The following is a description of a gene set: part of: Diseases associated with the TLR signaling cascade Myeloid differentiation primary response (MyD88) is an adaptor protein that mediates intracellular signaling pathways evoked by all Toll-like receptors (TLRs) (except for TLR3) and several interleukin-1 receptors (IL-1Rs) (Medzhitov R et al. 1998). Upon ligand binding, TLRs hetero- or homodimerize and recruit MyD88 through their respective TIR domains. Then, MyD88 oligomerizes via its death domain (DD) and TIR domain and interacts with the interleukin-1 receptor-associated kinases (IRAKs) to form the Myddosome complex (MyD88:IRAK4:IRAK1/2) (Motshwene PG et al. 2009; Lin SC et al. 2010). The Myddosome complex transmits the signal leading to activation of transcription factors such as nuclear factor-kappaB (NFkB) and activator protein 1 (AP1).<p>Studies have identified patients with autosomal recessive (AR) form of MyD88 deficiency caused by homozygous or compound heterozygous mutations in MYD88 gene leading to abolished protein production (von Bernuth et al. 2008). AR MyD88 deficiency is a type of a primary immunodeficiency characterized by greater susceptibility to pyogenic bacteria such as invasive pneumococcal disease manifested in infancy and early childhood. Patients with MyD88-deficiency show delayed or weak signs of inflammatory responses (Picard C et al. 2010; Picard C et al. 2011).<p>Functional assessment of MyD88 deficiency revealed that cytokine responses were abolished in patient-derived blood cells upon stimulation with bacterial flagellin, which is recognized by TLR5 (von Bernuth et al. 2008). An NFkB luciferase reporter gene assay using human embryonic kidney 293 (HEK293T) cells showed that MyD88 variants, S34Y, E52del, E53X, L93P, R98C, and R196C, were compromised in the ability to enhance NFkB activation (Yamamoto T et al. 2014). The molecular basis for the observed functional effects (reported for selected mutations) probably faulty Myddosome formation due to impaired MyD88 oligomerization and/or interaction with IRAK4 (George J et al. 2011; Nagpal K et al. 2011; Yamamoto T et al. 2014).<p>While MyD88 deficiency might be expected to perturb MyD88?IRAK4 dependent TLR7 and TLR8 signaling events associated with the sensing viral infections in the endosome, patients with MyD88 and IRAK4 deficiencies have so far not been reported to be susceptible to viral infection. Reactome Pathway: MyD88 deficiency (TLR5) species: Homo sapiens, and this is the list of marker genes: MYD88 (MYD88 innate immune signal transduction adaptor), TLR5, fliC